The following is a description of a gene set: Mouse Gene Set: GOBP_GMP_SALVAGE studied in species Mus musculus Any process which produces guanosine monophosphate from derivatives of it, without de novo synthesis., and this is the list of marker genes: Hprt1, Adk, Ampd1, Impdh2, Ampd2, Ada, Aprt, Gmps, Pnp, Impdh1